Given this list of marker genes PRKCD, GGTA1, RASA4B, MAOA, CITED2, PTGS2, CYTH3, GEM, CCN1 (NCBI Gene Id 3491), CSRP1, SIRT2, GLMP, ASAP1, EIF4B, CCL15, SNX6 (sorting nexin 6), SFRP2, CLIC1, STXBP3, TPD52L1, PLK2, THBS2, SKAP2, SPP1, GSTT1, CDKN2A, CSF1, LGALS9, TSPYL4, CNN3, NEDD9, FZD2, LATS2, GRN, MAGED2, KIFAP3, RECK, MFSD1, NDRG4, CDK4, RASSF5, ARMCX2, CXCL12, FERMT2, CDKN2B, PLA2G4A, TPM1, FOS, ID3, CCL7, DOK1, GSTM5, ACOT9 (acyl-CoA thioesterase 9), GPC4, DNM1, NME4, C16orf89, GAS2, SPART, F3, ANXA11, RNF13, CTNND1, CCL2, FADS1, EXOC4 (exocyst complex component 4), KLF4, AKAP12, ROCK2, DDAH2, PCGF5, CEBPD, ACVR2A, SLC8A1, GALK2, PLAT, EPHX1, TXNDC16, DPP7, PHLDA1, HEBP1, JUP, VCAM1, IFI30, BCAR1, here is a description of the gene set: from publication Burton GR, Nagarajan R, Peterson CA, McGehee RE Jr (PMID 15033539) species: Mus musculus Strongly down-regulated at 8-96 h during differentiation of 3T3-L1 cells (fibroblast) into adipocytes. Human Gene Set: BURTON_ADIPOGENESIS_9 During cellular differentiation and development, it is recognized that many complex molecular mechanisms as well as precise patterns of differentially expressed genes occur in directing precursor cells toward a given lineage. Using microarray-based technology, we examined gene expression across the course of 3T3-L1 adipocyte differentiation. Total cellular RNA was isolated at times 0, 2, 8, 16, 24, 48, and 96 h following treatment with either standard hormonal inducers of differentiation; insulin, dexamethasone, isobutylmethylxanthine (IDX), or IDX plus trichostatin A (TsA), a histone deacetylase inhibitor and potent adipogenic inhibitor. cRNA was synthesized from cellular RNA and hybridized to high density Affymetrix MG_U74Av2 microarray gene chips containing 12,488 cDNA/Expressed Sequence Tags (ESTs) probe sets. From the IDX-only treated cells, all probe sets that were either unchanged or differentially expressed less than 2-fold throughout differentiation with respect to time 0 preadipocytes were excluded from further analyses. This selection resulted in a net of 1686 transcripts, 859 were increased in expression, and 827 were decreased in expression at least 2-fold across differentiation. To focus in on genes that were more specific to differentiation, the same analysis was performed on IDX plus TsA-treated non-differentiating cells and all probe sets from the IDX-only group that exhibited similar expression profiles in the non-differentiating TsA-treated group were excluded leaving a total of 1016 transcripts that were regulated only under differentiating conditions. Six hundred and thirty-six of these transcripts were elevated at least 2-fold and 380 exhibited a decrease in expression relative to time 0 preadipocytes. This group of genes was further analyzed using hierarchical clustering and self-organizing maps and resulted in the identification of numerous genes not previously known to be regulated during adipocyte differentiation. Many of these genes may well represent novel adipogenic mediators and markers of adipogenesis.